The following is a description of a gene set: Human Gene Set: HP_PAROXYSMAL_SUPRAVENTRICULAR_TACHYCARDIA Paroxysmal supraventricular tachycardia An episodic form of supraventricular tachycardia with abrupt onset and termination. species: Homo sapiens, and this is the list of marker genes: BMP2, TNNI3K, SPRED1, SLC19A2, LMNA